Given this list of marker genes THOC6, RAB9A, INSL6 (NCBI Gene Id 82352), GPR4, CFLAR, STAP2, SFMBT2, SLC4A8, C1orf122, PSIP1, ICAM1, SPSB1, SPIB, NUDT17, MYO1C, ARHGAP28, ZFAND3, EGF, PRNP, TAP2, NXF1, TM9SF4, USE1 (unconventional SNARE in the ER 1), ZYX, MXI1, IL4R, DHX58, COQ10B, GCH1, HTRA1, SERPINB9, SIAH1, DDX60, AP1G2, MX1, DENND3, PDCD10, ZBTB10, STAT1, GRK5, AKAP9, LDLR, CAPN10, CLK3, PLSCR1, BASP1, TGIF1, SAMSN1, AGFG1, CMTR1, CDYL, ARL13B, SLU7, GUCD1, POLR3C, PIAS1, PCGF5, IRF7, PLA2G4F, UBA7, NKIRAS2, ARHGAP1, CDC42EP3, PRDM1, NIPAL1, ARF4, UBALD2, HSPA1A, ADPRM, NID1, ZUP1, MYH10, EMD, IL6, ARHGEF10, PATL1, IL15, RAB21, PIAS3, DOP1B, DUSP14, TSPAN3, STOML1, NUB1, GTDC1, PPHLN1, NFAT5, SLFN5, DNAJC12 (NCBI Gene Id 56521), SDF4, PLCG1, CREBL2, RNF19B, ZNHIT3, EPB41, IL4I1, DYNC1LI1, CD274, RNF24, ZBTB32, KTN1, KIAA0040, USP18, KMT2A, PNPLA2, ENO2, SLAIN2, CYTH1, NFKB1, STAT2, GALE, GYPC, GPR183, PEF1, MED31, RNF214, MND1, OGFRL1, ETV3, ISCU, CMPK2, TRAK1 (NCBI Gene Id 22906), REL, GABPB1, MRPS7, PPP1R15B, CLN3, DUSP16 (dual specificity phosphatase 16), CHMP3, GTPBP1, TLCD1, PKN2, APAF1, MEX3B (NCBI Gene Id 84206), ATP11A, SLC25A1, CXCL11, CSRNP1, ACADM, VDR, ERCC3, PRDM4, CACNB3, SLC4A11, GPBP1, NMNAT1, INPP5B, MAPK6 (mitogen-activated protein kinase 6), PPP6R1, HAT1, ZBED4, TMEM106A, CLIC4, ETNK1, PML, IL2RA, VPS54, RGS12, XPO6, CXCR5, ACVR2A, IL1RN, MRPS6, PPM1K, CNIH4, SELPLG, FBXL3, RALGAPA2, OAS2, ARIH1, PER1, NUP85, REST, TRAF2, CD226, IL15RA, SLC49A4, TNIP2, LRP8, TNFRSF9, TAGLN2, ADPRH (ADP-ribosylarginine hydrolase), HNRNPA1, PDCD1, PIP5K1A, ETFA, SEMA7A, SERINC5, NT5C3A, HSD17B7, IFT22, NOSTRIN, ZC3H10 (zinc finger CCCH-type containing 10), CCR7, STAT4, PARP14, VSIG10, TMEM150C, ELP5, here is a description of the gene set: Human Gene Set: GSE42724_MEMORY_BCELL_VS_PLASMABLAST_UP Genes up-regulated in B lymphocytes: memory versus plasmablasts. studied in species Homo sapiens from publication Covens K, Verbinnen B, Geukens N, Meyts I, Schuit F, Van Lommel L, Jacquemin M, Bossuyt X (PMID 23613519) The recent discovery of the human B1 cells, identified by the expression of CD20, CD27 and CD43 in absence of expression of CD70 and CD69 has been subject of debate. Some studies have raised the possibility that these cells are B cells differentiating towards the plasmablast and plasma cell stage rather than being the human counterpart of murine B1 cells. No further in depth studies have been performed. Therefore, a functional comparison was made between, the proposed B1 cells and plasmablasts. We observed that for several functional characteristics (distribution of isotypes of spontaneously producted antibodies, production of antigen-specific antibodies after vaccination with both T-cell dependent as well as T-cell independent antigen, the proposed B1 cells behaved similar to plasmablasts. In addition, we were able to differentiate the proposed B1 cells in vitro, indicating that they are not from a distinct lineage as the murine B1 cells. Gene expression analysis revealed that these cells cluster between memory B cells and plasmablasts, contradicting them being the genuine human counterpart of murine B1 cells, rather revealing a preplasmablast phenotype.